The following is a description of a gene set: Any process that activates or increases the frequency, rate or extent of the division of the cytoplasm of a cell, and its separation into two daughter cells. Human Gene Set: GOBP_POSITIVE_REGULATION_OF_CYTOKINESIS species: Homo sapiens, and this is the list of marker genes: OR1A2, CDC25B, GIPC1, AURKC, RXFP3, ECT2, OPN1MW, DRD2, CHMP3, PRKCE, PKP4, OR2A4, BIRC5, CIT, WNK1, NUP62, EXOC7, CUL3, CDC6, KIF3B, KIF23, CENPV (centromere protein V), MRGPRX2, CDCA8, CDC14A, SPAST, OPN1LW, OPN1MW2, INCENP, RHOA (NCBI Gene Id 387), PKN2, CDC42, POLDIP2, CDC14C, RACGAP1, MAP10, CSPP1, ARF6 (NCBI Gene Id 63379), RAB11A, KIF20B, TAS2R13, SSTR5, DRD3, KIF14, SVIL, AURKB, CDC14B, TAS1R2, CXCR5, RAB11FIP3